Given this list of marker genes LCP2 (lymphocyte cytosolic protein 2), RAC2 (NCBI Gene Id 5880), IL2RG, EXTL3, RPA1 (replication protein A1), BCL11B, STN1, PSMB10, DCLRE1C, PSMB9, FOXN1, here is a description of the gene set: Human Gene Set: HP_ABNORMALLY_LOW_T_CELL_RECEPTOR_EXCISION_CIRCLE_LEVEL Reduced level of T cell receptor excision circle (TRECs) as measured by the TREC assay. Late in maturation, 70% of thymocytes that will ultimately express alpha/beta-T cell receptors form a circular DNA TREC from the excised TCRdelta gene that lies within the TCRalpha genetic locus. The circles are stable but do not increase following cell division and, therefore, become diluted as T cells proliferate. A quantitative polymerase chain reaction (PCR) reaction across the joint of the circular DNA provides the TREC copy number, a marker of newly-formed, antigenically-naïve thymic emigrant T cells. Abnormally low T cell receptor excision circle level studied in species Homo sapiens